The following is a description of a gene set: Human Gene Set: MODULE_249 Genes in the cancer module 249. studied in species Homo sapiens, and this is the list of marker genes: CPT1A, F13A1, TGM1, NAT2, SPTLC2, GLYAT, CPT2, DLST, GGT1, HADHB, HADHA, QPCT, BAAT, ACAT1, DBT, GGTLC1, ACAA2, HAT1, SAT1, NAT1, ALAS1, LCAT (lecithin-cholesterol acyltransferase)